The following is a description of a gene set: studied in species Mus musculus Mouse Gene Set: chr12B1, and this is the list of marker genes: Arl4aos, Gm7008, Gm19220, Gm7239, Gm26326, Gm46348, Gm18591, Gm46349, Gm7242, Ifrd1, Gm18246, Gm18116, Gm19441, Gm4263, Gm10165 (NCBI Gene Id 791391), Gm24434, Lsmem1 (NCBI Gene Id 380755), Mir1938, Gm18954, Arl4a, Immp2l, Gm34923, Gm18939, Gm33340, Scin, Lrrn3, Dock4, Zfp277, Gm24069